The following is a description of a gene set: species: Homo sapiens Human Gene Set: chr11q11, and this is the list of marker genes: OR5D13, OR5D2P, TRIM48, OR4A7P (olfactory receptor family 4 subfamily A member 7 pseudogene), OR4A21P, OR4V1P, OR4A50P, OR5D3P, OR4A2P, OR4A10P, OR4C1P, OR4S2, OR4C16, OR4A4P, OR4A11P (olfactory receptor family 4 subfamily A member 11 pseudogene), OR4A16, OR5D14, OR4X7P, TRIM51HP, OR4C7P, OR4A13P, OR5D17P, OR4C11, OR4C14P, OR4A9P, OR4P4, OR5D15P, OR4A5, OR4C50P, OR4C6, OR4A17P, OR4P1P, OR4A6P, OR4C15, OR4A3P, OR4C46, OR4R2P, OR4A8, OR4A15, OR4A12P